The following is a description of a gene set: species: Homo sapiens Human Gene Set: GOBP_B_CELL_MEDIATED_IMMUNITY Any process involved with the carrying out of an immune response by a B cell, through, for instance, the production of antibodies or cytokines, or antigen presentation to T cells., and this is the list of marker genes: IGLL5, C7, IGHV7-81, LTA, IGHA1, TNFSF4, IGHV3-49 (immunoglobulin heavy variable 3-49), IGHV3-23, IGHV2-5, CD27, C5 (NCBI Gene Id 727), IGLC3, IGHV3-38, CD40, IGHV5-10-1, EXOSC3, CR1L (NCBI Gene Id 204855), CD81, C17orf99 (chromosome 17 open reading frame 99), TREX1, C1R, NDFIP1, TREM2, IGHV8-51-1 (immunoglobulin heavy variable IGHV8-51-1 (non-functional)), CSF2RB, NSD2, RIF1, IGLC6, C4BPA, IL2, BTK (NCBI Gene Id 695), C1QB, IL9R, IGHV3-73, BATF, CLU, MLH1, IGHE, FCGR1BP, SHLD1, SANBR, SWAP70 (switching B cell complex subunit SWAP70), IL13RA2, EXO1, C1QA, FOXP3, C1QC, IGHV1-3, CR1, IGHV3-48, CD28, C1S, PMS2, C8B, TNFSF13, FCGR2C, C9, IGHG1, CD74, IGHV1-69, IGHG3, MSH6, MBL2, IGHV1-69-2, C3, IGHV6-1, IGHV4-4 (NCBI Gene Id 28401), ATAD5, AICDA, IGLC2, HLA-E, IGHV3-20, IGHV4-31, CD55, IGHV3-35, PTPN6, RNF168, IGHV5-51, XCL1, PARP3, EXOSC6, MYD88, MAD2L2, FCGR1A, C1RL, IGHV4-34, IGHV2-70, C2, MSH2, IGHV2-26, CD19, FCGR3B (Fc gamma receptor IIIb), IGHV1-58, IGKC, CD40LG, HLA-G, IGHV3-16, TLR8, IGHV3-33, TP53BP1, IGHV7-4-1, SUSD4, NFKBIZ, IGHV1-18, CARD9, IGHG4, IL2RB, IL4R, C8G, IGHV4-59, ERCC1, IGHV3-13, IRF7, TRAF3IP2, PCYT1A, C1QBP, BCL3, NBN (nibrin), IGHV1-24, KMT5B, IGHV4-61, RNF8, IGHD, IGHV3-53 (NCBI Gene Id 28420), IGLC1, SHLD3, IGHA2, IGHV3-7, TCIRG1, SLC15A4, IGHV3-43, CLCF1, HSPD1, FCER2, C8A, NECTIN2, HPX, TGFB1, IGHV3-11, MASP2, IGLL1, IL10, SERPING1, IGHV3-66, FOXJ1, IGHG2, CD226, UNG, HMCES, C4A, SHLD2, IGHV4-39, TBX21, FCGR2A, FCRLB, C4BPB, SLA2, TNF, CCR6, CD46, IL9, PAXIP1, FCER1G, SUPT6H, FCGR3A, CD70, STAT6, PRKCD, IGHV3-72, IGHV3-74, PTPRC, BCL6, IL4, IGHV1-69D (NCBI Gene Id 102723169), IL27RA, IGHV3-30, IGHV1-45, IGHV3-64D, IGHV2-70D, BCL10, FCER1A, IGHV3-64, IGHV3-21, IGLC7, C6, CR2, C4B (complement C4B (Chido/Rodgers blood group)), KMT5C, FCGR2B (Fc gamma receptor IIb), IGHV3-15, APLF, INPP5D, ZP3, IGHV4-28, TFRC, LIG4, CFI, FCMR